Given this list of marker genes ZBTB20, ITGB1, CANT1, VPS26C, CD28, SIT1, CSNK1G2, BANP, SLC4A7, APBB1IP, SRPRB, CD2, MAP3K12, ITGB7, NDRG3, ATXN7L3, RANBP9, NAB2, SGTA, SLC30A5 (NCBI Gene Id 79021), POU2F1, PYGO2 (pygopus family PHD finger 2), DPF2, USP4, LGMN, TERF2IP, FEM1A, ADGRE5, CDK16 (NCBI Gene Id 5127), TCF25, ITM2C, LBP, CD6, SETD4, ICE1, KCNN4, MMP15, CD5, ARRB1, SKIC2, ZNF467, NISCH, MYCBP2, TNFRSF4, YWHAB, PCID2, MEPCE, TSPAN32, ADCY6, STARD3, AKAP8L, MPRIP, PRKD2, TK2, CCR6, CWC22, CFL2, ITPK1, CTSH, IGHM, OTULINL, CD2AP, INVS, HBB, PDLIM4, DLG3, GGT5, ANGPTL2, RGS11, RAB35, DAG1, SMARCA4, NEURL4, CD99L2, VKORC1, EZH1, GLTP, ZSCAN26, PDK1, HLA-E, RFLNB, FLOT2, ORMDL3, PPID, SNX5, RGL2, DVL1, DUSP1, HBA2, MFHAS1 (multifunctional ROCO family signaling regulator 1), GRAP2, IGKC, SEMA4B, SMPD2, S1PR4, SKI, INPP5K, HLA-DQA1, TMC6, TPGS2, USP10, POLR2A, CASK, TRAPPC12, SOCS3, TRMT1, STIP1, LDB1, LMO2, FKBP8, EIF4EBP2, CREBBP, PKD1, GABRR2, ARFGAP2, PBX2, SAFB, TSC22D4, IGLC7, ANKS3, CHERP, SPNS1, RPL30, BOD1L1, SNX2, CYP2S1, RGS14, MAPK14, IRF6, NXF1, BCL2L2, DNTT, FAS, TTC17, LDHB, FASLG, EXT1, EIF4G2, IER2, GRK6 (G protein-coupled receptor kinase 6), SF3A2, SMARCD2, HSD17B11, CLCN4, RGS19, PRF1, ITGA6, IDUA (NCBI Gene Id 3425), TOR1B, MARK2, SELL, STUB1, USE1, MCM3AP, IL16, TOX4, MLEC, ARID3B, SGK1, CLEC3B, OTUD5, COPS2, ASH1L, PPP2R5A, CD79A, PIK3C3, ABCF3, RMND1, SIDT2, ST3GAL1, WBP2, PJA1, BABAM1, MAN2B1, CASP4, CBFA2T2, SETDB1, RUFY1, RPS6KA2, FCRLA, ATP1A1, IRF3, HOPX, CD19, RCAN3, CRYBG1, CCR7, DGKA, SPICE1, IL27RA, SIPA1, RABAC1 (NCBI Gene Id 10567, Rab acceptor 1), HNRNPA1, PPP4C, CIC, TAP1, IL6R, ABHD8, ARHGAP45, CD22, here is a description of the gene set: Mouse CD8+ T cells affected by ID3 (Inhibitor of DNA binding 3) display patterns of gene expression suggesting enhanced persistance and survival. In this study, we identified genes differentially expressed between ID32a transduced and mock transduced, and ID32a knockout and wild type mouse CD8+ T cells. Most prominent functions of differentially expressed genes include DNA replication-associated repair, maintenance of chromosome stability and mitotic cell divison machinery. Overall, these data suggest that ID3 acts in favor of maintained survival in CD8+ mouse T cells. Genes up-regulated in CD8 T cells: control versus over-expressing ID3. studied in species Homo sapiens Human Gene Set: GSE23568_CTRL_VS_ID3_TRANSDUCED_CD8_TCELL_UP from publication Ji Y, Pos Z, Rao M, Klebanoff CA, Yu Z, Sukumar M, Reger RN, Palmer DC, Borman ZA, Muranski P, Wang E, Schrump DS, Marincola FM, Restifo NP, Gattinoni L (PMID 22057288)